Given this list of marker genes GNA15, ABHD6, RLN2, TAS2R1, GNAI3, ARHGEF10, CCL28, NET1, PDE7A, CCR5, PIK3R2, CCR2, GNG7, CCR9, TAS2R43, C5AR1, P2RY6, KNG1, SRC, GPR132, CXCL2, OXT, OXER1, PDE4A (NCBI Gene Id 5141), HRH2, ARHGEF2, HBEGF, ADRB2, PLA2G4A, MCHR1, CXCL10 (C-X-C motif chemokine ligand 10), ARHGEF40, ADRA2C, NPY5R (NCBI Gene Id 4889), TAS2R30, UTS2R, PDE8A, TAS2R4, TAS2R46, ITPR1, ARHGEF37, GNAQ, CXCL5, GNAI1, GNAT2, GPR17, CCL21, CAMK2B, PROKR2, EDNRA, GRK2, GNGT1, PTH2, AKT3, P2RY1, GABBR2, ECT2, ADCY3, GPHB5, PIK3R1, GRM6, BRS3, DGKH, TAS2R38 (taste 2 receptor member 38), TAS2R3, EGFR, HRAS, PF4, PRKACG, DRD3, TAAR9, PRKCB, RGS14, RGS6, ADRA1A, GPR176, CCL25, GNG10, MTNR1A, TRPC3 (transient receptor potential cation channel subfamily C member 3), GPR15, TIAM2, NPFFR1, MLNR (NCBI Gene Id 2862), TAAR5, KRAS, EDN2, RGS1, CXCR5, F2RL2 (coagulation factor II thrombin receptor like 2), PROK2, DGKA, PTH2R, PPP2R5D, GNRH1, ANXA1, DGKQ, RGS17, PTH, NPY1R, PRKCH, PDE10A, BTK, CCL19, GHRH, GNG12, ADM2, S1PR4, GNAT3, CALCA, CHRM3, GPR37L1, GIP, HCAR1, GNA12, FPR2, TRPC7 (NCBI Gene Id 57113, transient receptor potential cation channel subfamily C member 7), CCL1, UTS2, CNR1 (cannabinoid receptor 1), OPN1LW, PRKCE, TAS2R16, TAS2R60, PDYN, TSHR, F2, AGT, SCTR, RGS4, TRHR, HTR2C, NPSR1, EDN1, PNOC, GNA11, POMC, DGKD, INSL5, GNG4, ADCY2, PLEKHG2, CXCL13, RHOB, PLCB4, LPAR6, HRH1 (NCBI Gene Id 3269), AKT1, RGS20, TAAR8, NTSR1, CDK5, LPAR2, PLCB1, PIK3CA, TAS2R45, RLN3, TACR2, GRK5, APP, MCF2L, NPB, GPR39, TAS2R41, GPR18, RASGRF2, CCL23, CDC42, GCG, GAST, HTR2B (NCBI Gene Id 3357), GNB2, TAC3, CGA, TAS2R31, GNAZ, TAS2R50, ITSN1, RPS6KA3, CCR6, GPR45, CCL5, GPR143, GABBR1, GALR3 (NCBI Gene Id 8484), PDE4C, ADCY7, FFAR3, BDKRB1, TAAR6, MT-RNR2, PROKR1, DRD5, CASR, AVPR1B, GPR68, GPRC6A, RHO, CCR4, PIK3R5, ITPR2, PRKAR2B, PRKAR2A, GNAS, GLP2R, RPS6KA1, GPR27, GPR55, HCRTR1, RGS11, PDE3A, GNG11, OXGR1, GRM2, ARRB2, HRH4, PDE1B, NTS, PDE7B, CCL4L1, ADCY1, CXCL16, GPR37, PDE4B, PRKAR1B, GALR2 (galanin receptor 2), NPY2R, DGKG, PRKCD, C3, SHC1, CHRM4, P2RY2 (NCBI Gene Id 5029), OPRK1 (opioid receptor kappa 1), GLP1R, SSTR3, ACKR3 (atypical chemokine receptor 3), ADRA2B, AGTR2, LHCGR, DRD1, CCR8, CXCL11, GPHA2, RGS19, TAS1R1, CCL16, GRPR, CCK (cholecystokinin), GPR4, ADRA1D (adrenoceptor alpha 1D), RXFP2, OBSCN, CORT, ADCYAP1, TACR1, TAAR2, XCL1, PTGER1, S1PR3, GNG5, PMCH, LPAR4, EDNRB, GNG13, GPSM1, MAPK1, ADRA2A, PROK1, HTR1B, RGS21, CCR7, MAPK7, CRH, GPR83, PTGFR, CXCL1, DGKI, AVP, TAS2R19, KISS1R, CHRM5, ARHGEF18, ITGB1, NBEA, CCL20, PIK3R3, TAS2R42, SSTR5, GRM3, GNAL, ADORA1 (NCBI Gene Id 134), NMUR1, FGD4, FPR1, SOS1, MC4R, GRM1, NMU, GNA14, PTGER4, MGLL, GIPR, DAGLB, OPN5, C5, GRM8, GRM4, CYSLTR2, PPP2CB, ARHGEF1, CXCL6, GPSM3, LPAR1, S1PR2, OPN4, AVPR2, GNAI2, TACR3, NPFFR2, TAS2R40, SSTR4, VIP, HTR7, PPP3CB, PDE8B, NPY, BDKRB2 (bradykinin receptor B2), TAS2R7, PDPK1, P2RY11, KALRN, LTB4R, PRKAR1A, CXCR1, PTGER3, SUCNR1, GHRL, NMBR (NCBI Gene Id 4829), CALCRL, APLNR, GNA13, GPR20, CALCR, KPNA2, P2RY4, CXCR2 (C-X-C motif chemokine receptor 2), RGS9, SST, DGKE, RPS6KA2, DGKZ, RGS12, VAV3, DGKB, CCL27, PDE1A, PDE2A, PTGER2, OPN1SW, HTR4, HTR1E, GPR84, ARHGEF19, PPP3R1, MCHR2, NMB, ARHGEF11, RXFP4, GPR65, TAS2R9, PRKACA, NPS (NCBI Gene Id 594857), TSHB (thyroid stimulating hormone subunit beta), CXCR3, NPW, RASGRP1, ARHGEF17, PPP2R1B, TRH, CAMKK1, QRFPR, HCRTR2, ADM, PLEKHG5, OXTR, SCT, CXCL12, PTAFR, MTNR1B, NPY4R, HTR5A, KISS1, FSHB, MC3R, NPBWR1, RAMP1, HTR2A, LPAR5, RGS7, TAS1R3 (taste 1 receptor member 3), CXCL3, RAMP2, ADRB1, RGS16, MC1R, ADCY6, ARHGEF7, EDN3, ARHGEF16, SOS2, GNB3, PRKACB, TAS2R20, OPN3, PDE3B, MAPK3, GPR183 (G protein-coupled receptor 183), GPR150, GNRHR2, TIAM1, TAAR3P, ARHGEF12, CCKBR, OPRD1, GHRHR, GNG2, CHRM1, QRFP, AKT2, SAA1, RGS22, ARHGEF9, PDE4D, PDE11A, PENK, PPP3CA, PRKCG, PRKX, GNB4, FGD2, RAMP3, CX3CL1, VIPR1, FGD3, P2RY14, NGEF, HTR1F, AVPR1A, TAS2R39, XCL2, PTGDR (prostaglandin D2 receptor), MLN, RASGRP2, GHSR, TAS2R5, ARHGEF6, CAMKK2 (calcium/calmodulin dependent protein kinase kinase 2), CXCL9, NMUR2, ABR, PIK3CG, GNRHR, RGS3, F2R, TRPC6, TAS2R13, PTH1R, FN1, GPR25, ARHGEF15, CALM1, PPP1CA, ITGA5, MC5R, GNG3, HTR6, ADRA1B, ADRB3, PSAP, PCP2, C3AR1, RGSL1, GCGR, ADORA2A, LPAR3, FGD1, P2RY10, ADORA3, GRM7, AHCYL1, GNB1, GRK3, OPRM1, GRK6, ARRB1, RXFP3, ITPR3, HTR1D, IAPP, PLXNB1, CNR2, CAMK4, OPRL1, TAS2R14, PRKCQ, GNGT2, CAMK2G, PPY, ROCK1, HCAR3, DAGLA, CX3CR1, GNRH2, PTGDR2, RHOA, GRB2, VIPR2, PRKCA, NRAS, PLCB2, LTB4R2, INSL3, ADORA2B, RXFP1, PPP3CC (protein phosphatase 3 catalytic subunit gamma), NPFF, HCAR2 (hydroxycarboxylic acid receptor 2), PPP1R1B, GRM5, ADCY4, TAAR1, PDE1C (phosphodiesterase 1C), ARHGEF25, RGS2, PPP2CA, ROCK2, HCRT, RRH (NCBI Gene Id 10692), ARHGEF10L, CCR3, FPR3, ARHGEF39, ARHGEF38, RGS8, NPBWR2, GNG8, ARHGEF33, PYY, TAS2R8, PPBP, ADCY8 (NCBI Gene Id 114), VAV2, CRHR1, ARHGEF26, DRD4, P2RY12, CALCB, TAC1, CYSLTR1, PREX1, PLCB3, TAS1R2, ADCYAP1R1, CCKAR, CXCR6, SSTR2, ARHGEF5, CCL13, FFAR2, CAMK2D, GPSM2, RGS5, XCR1 (NCBI Gene Id 2829), PPP2R1A, GALR1, PIK3R6, GNB5, TRIO, GPER1, CXCR4 (NCBI Gene Id 93405), CCR10, GNAT1, VAV1, GPR32, P2RY13, LHB (NCBI Gene Id 3972), S1PR5, TBXA2R, CAMK2A, NMS, MMP3 (NCBI Gene Id 4314), CCL4, AGTR1, RGS18, DGKK, CHRM2 (cholinergic receptor muscarinic 2), CREB1, GRP, F2RL1, PAK1, SSTR1, NTSR2, FSHR, RGS10, CCR1 (NCBI Gene Id 1230), UTS2B, RHOC, GPR31, ARHGEF35, GAL, GPBAR1, APLN, PTHLH, FFAR1, RGR, CRHR2, TAS2R10, OPN1MW, F2RL3, HEBP1, MCF2, ADCY5, CXCL8, ADCY9, FFAR4, ARHGEF4, PTGIR, ABHD12, AKAP13, MC2R, RGS13, ARHGEF3, here is a description of the gene set: G protein-coupled receptors (GPCRs) are classically defined as the receptor, G-protein and downstream effectors, the alpha subunit of the G-protein being the primary signaling molecule. However, it has become clear that this greatly oversimplifies the complexities of GPCR signaling (Gurevich & Gurevich 2008). The beta:gamma G-protein dimer is also involved in downstream signaling and some receptors form metastable complexes with accessory proteins such as the arrestins. GPCRs are involved in many diverse signaling events, using a variety of pathways that include modulation of adenylyl cyclase, phospholipase C, the mitogen activated protein kinases (MAPKs), extracellular signal regulated kinase (ERK) c-Jun-NH2-terminal kinase (JNK) and p38 MAPK. Regulator of G-protein Signalling (RGS) proteins can directly inhibit the activity of the G-alpha subunit. The general function of the G alpha-s subunit (Gs) is to activate adenylate cyclase, which in turn produces cyclic-AMP (cAMP), leading to the activation of cAMP-dependent protein kinases (often referred to collectively as Protein Kinase A). The signal from the ligand-stimulated GPCR is amplified because the receptor can activate several Gs heterotrimers before it is inactivated. The classical signalling mechanism for G alpha-i (Gi) is inhibition of the cAMP dependent pathway through inhibition of adenylate cyclase. Decreased production of cAMP results in decreased activity of cAMP-dependent protein kinases. G alpha-z (Gz) is a member of the Gi family. Unlike other Gi family members it is pertussis toxin-insensitive. Gz interacts with Rap1 GTPase activating protein (RAP1GAP) to attenuate Rap1 signaling. The classic signalling route for G alpha-q (Gq) is activation of phospholipase C beta, leading to phosphoinositide hydrolysis, calcium mobilization and protein kinase C activation. This provides a path to calcium-regulated kinases and phosphatases, GEFs, MAP kinases and many other proteins. The G-alpha-12/13 (G12/13) family is probably the least well characterized, at least in part because G12/13 coupling is more difficult to determine than for other subtypes, G12/13 is best known for involvement in the processes of cell proliferation and morphology, such as stress fiber and focal adhesion formation. Interactions with Rho guanine nucleotide exchange factors (RhoGEFs) are thought to mediate many of these processes. (Buhl et al.1995, Sugimoto et al. 2003). Activation of Rho or the regulation of events through Rho is often taken as evidence of G12/13 signaling. Receptors that are coupled with G12/13 invariably couple with one or more other G protein subtypes, usually Gq. species: Homo sapiens part of: Signaling by GPCR Reactome Pathway: GPCR downstream signalling